Given this list of marker genes Ptgis, Dynll1, Khsrp, Tspo, Oprm1, Gla, Wdr35, Il4, Rgn, Acp5 (acid phosphatase 5, tartrate resistant), Il10, Sirpa (NCBI Gene Id 99074), Gimap3, Cav1, Epor, Rock2, Zc3h12a, Gimap5, Atp2b4, here is a description of the gene set: Any process that stops, prevents or reduces the frequency, rate or extent of nitric oxide metabolic process. Mouse Gene Set: GOBP_NEGATIVE_REGULATION_OF_NITRIC_OXIDE_METABOLIC_PROCESS studied in species Mus musculus